The following is a description of a gene set: Genes up-regulated in T reg following anti-CD3 in vivo treatment versus control. from publication Nishio J, Feuerer M, Wong J, Mathis D, Benoist C (PMID 20679403) Human Gene Set: GSE22527_ANTI_CD3_INVIVO_VS_UNTREATED_MOUSE_TREG_UP Treatment with anti-CD3 is a promising therapeutic approach for autoimmune diabetes, but its mechanism of action remains unclear. Foxp3+ regulatory T (Treg) cells may be involved, but the evidence has been conflicting, and there is great uncertainty as to possible mechanistic connections. We investigated this issue in mice derived from the NOD model, which were engineered mice in which Treg populations were perturbed, or could be manipulated by acute ablation or transfer. The data highlighted the involvement of Foxp3+ cells in anti-CD3 action. Rather than a generic influence on all Treg cells, the therapeutic effect seemed to involve an striking expansion of previously constrained Treg cell populations; this expansion occurred not through conversion from Foxp3- Tconv cells but from a dramatic proliferative expansion. We found that Treg cells are normally constrained by TCR-specific niches in secondary lymphoid organs, and that intraclonal competition restrains their possibility for conversion and expansion in the spleen and lymph nodes, much as niche competition limits their selection in the thymus. The strong perturbations induced by anti-CD3 overcame these niche limitations, in a process dependent on receptors for trophic cytokines, interleukin-2 receptor (IL-2R) and IL-7R. studied in species Homo sapiens, and this is the list of marker genes: BLZF1, HS3ST2, LRRFIP2, MELTF, GPR6, KCNK1, CSF2, SND1-IT1, S1PR5, MKRN3, PITPNA, CLSTN2, PKD2L1, ELP5, SCARF1, PMM2, RBM15, TNFSF14, SCARB2, ARHGEF10, MTF1, PORCN, OR1E1, SIRT6, CPZ, BTN1A1, SRSF5, CHGA, CUX2, TGFBR2, GADD45G, TMEM39A, HOXB9, TYR (tyrosinase), SAR1A, SYBU, ZNF274, CDC42BPB, PKNOX2, MMP11, RNF208, RNF10, RFX1, SERPINB3, TMEM51, PLEK2, AMD1, KLC1, TNFRSF12A, SPTB, AMBP, LMNA, CD44 (CD44 molecule (IN blood group)), TRBC1, MYH9, ITPR3, C11orf24, MORF4L2, MTSS2, PPP1R11, SH2B3, ECD, PHF1, ST3GAL5, CEBPE, CYP11B2, CTTN (cortactin), PTP4A3, TMEM87A, CHRM4, MUC2, PPIF, ACTR3, MOAP1, UPK3A, CD59, TFG, CMC2, P2RX1, WNT7A, CTRC, AUTS2, CLK1, SACS, PRDM2, LILRA5, DR1, PPY2P, MPPED1, CBL, S100A11, FBXO28, ADA, RXRA, ELK4 (ETS transcription factor ELK4), SP100 (SP100 nuclear antigen), SLC8A2, MAGEB2, CD82, MAP3K19, GAK, CLCN3, TMEM74B, MMUT, GPATCH2L, PGM5, MAMLD1, HMGA1, MAGEB3, CRYAA, EIF3I, FEM1C, GPR173, CCR8, LRRC42, KIF25-AS1, ME1, CNIH4, DNAJA1, ID2B, CHPF2, ARIH1, ING1, MAPK1, LMAN1L, MEX3C, MUC5AC, FPR3 (formyl peptide receptor 3), CREM, RHOBTB3, AFTPH, IPO7 (NCBI Gene Id 10527), LINC00472, USP34, CASS4, HCRTR2, AGAP2, TSGA10, DCP1A, NID1, AMMECR1, FCGR2B, PDE9A, STX1A, PFKFB2, GIT1, CCL17, RGS1, ADRB2, LCK (NCBI Gene Id 95387), CACNA1I, MLLT11, SOX14, CASZ1, FGB, KDM7A, TUBB2A, PLK3 (NCBI Gene Id 1263), GRM8, MACO1, LMCD1, TNNC2, IL6ST, STK25, HIPK2, ADRA1A, AEN, C22orf31, YBX3, PXN, CNN2 (calponin 2), MLANA, HGS, ACE, GRPR, CACNA1C, AGO3, TIMP1, CDK13, SLC27A2, DLST, GPR3, RAB3GAP1, TPT1P8, ADRA2C, IL1R2, PNMA1, SLC4A4, CLDN5, YES1, SLIT3, PFKFB3, MAGEL2, NRG1, MSMO1, HAPLN1, TSPOAP1, ZYX, CAPN2 (calpain 2)